Given this list of marker genes FRS2, MIR200B, BMP2, MIR590 (NCBI Gene Id 693175), DLL1, HDAC3, SMAD4, MIR222, DKK1, SOX6, FZD7, here is a description of the gene set: Human Gene Set: GOBP_NEGATIVE_REGULATION_OF_CARDIAC_MUSCLE_CELL_DIFFERENTIATION Any process that stops, prevents or reduces the frequency, rate or extent of cardiac muscle cell differentiation. species: Homo sapiens